Given this list of marker genes BCAS3, SLC39A8, ERLIN1, ORAI1, ALS2, PIGN, GNPAT (glyceronephosphate O-acyltransferase), ATP5F1D, DAG1, BICD2, IPO8, ADAMTS15, TPM3, GNS, MYL1, ANO5, KCNJ11, PYROXD1, MAP3K7, TGFB3, LARGE1, F8, SLC25A4, ABCC9, JAG2, NSUN2, PHF6, FKTN, ADAT3, SLC26A2, MYL11, TELO2, ERGIC1 (NCBI Gene Id 57222), BIN1, NALCN, SLC29A3, FLNA, KLHL9, FDFT1, GFM2, HNRNPA2B1, PNPT1, PSMB8, PTRH2, MMP1, PRG4, NT5C2, SGCA, BRF1, PPP2R5D, SLC39A14, UBA1, SLC25A46, SLC25A19, HRAS, PTH1R, FILIP1 (NCBI Gene Id 27145), SLC4A10, DYRK1A, BCOR, SDHB, TAF4, ABCC8, ERCC1, SIK3, FIG4, SYNE2, ITGA7, NEB, CRPPA, PIGY, KY, PDX1, DHX16, FHL1, ATP6V1E1, UNC80, GJB2, SLC10A7, COL12A1, MTMR14, TRPV4, TPM2, SPEG, COL6A1, POMT1, SPTBN4, RMRP, ZC4H2, SYNE1, PTDSS1, DPAGT1, EMD, CTDP1, COG8, TRIM2, DNM2, ERCC6, LMNA, ANKLE2, MEGF8, COL6A3, BAG3, KIAA0319L, DPM1 (NCBI Gene Id 8813), ESCO2, ABHD12 (abhydrolase domain containing 12, lysophospholipase), HSPG2, PI4KA, DDHD2, VARS1, ALG2, LGI4 (leucine rich repeat LGI family member 4), SPG11, PSAT1, MARS1, HINT1, CHRNB1, LMX1B, APC2, CPT2, GJB1, COL2A1, GARS1, LMBRD2, HS2ST1, SNAP25, COL6A2, MT-TE, TTN, GMPPB, SCYL2, HACD1, SPTAN1, GNB2 (NCBI Gene Id 96628), SDHAF1, MEGF10, ALAD, SLC18A3, NSD1, RNU4ATAC, OPA1, HLA-DRB1, NOD2, SRD5A3, DMD, FBN2, SLC12A6, SYT2, SDHD, RTTN, ZBTB20, SPTLC1, FKBP10, P4HTM, ERLIN2, CHRNG, MUSK, MYOT, SDHA, ACTA1, SCN4A, GJB6, MAP3K20, LBR, SLC6A9 (solute carrier family 6 member 9), JUP, FUS, FKRP, MYBPC1, CAPN3, PIEZO2, CNTNAP1, CAV1, FGFR3, GLI3, SGCG, RYR1, DSP, SCARF2, REEP1, STAT3, COL25A1, EIF5A, WDR26, ERCC4, PLAAT3, AMER1, MYO9A, MYH3, ABCD1, ADSS1, CCR6, C18orf32, LIFR, TBC1D2B, MMP2, KAT6B, ERCC8, IRF5, SIGMAR1, PIK3R2, NEDD4L, SLC1A4, PLEC, NGLY1, TNNT1, PSTPIP1, RPL10, DDR2, NFATC2, SELENON, C19orf12, GFPT1, INS, TMEM43, GNPTAB, SVIL, PIGA, KCNK9, ALG14, MYL2, UFC1, TOR1AIP1, PLOD2, FBN1, COL7A1, CCN2, GCK, STX5, here is a description of the gene set: Lower-limb joint contracture A limitation in the passive range of motion of a joint of the lower limb resulting from loss of elasticity in the periarticular tissues owing to structural changes of non-bony tissues, such as muscles, tendons, ligaments, joint capsules or skin. Human Gene Set: HP_LOWER_LIMB_JOINT_CONTRACTURE studied in species Homo sapiens